Given this list of marker genes RABL6, OTX2, GOLGA1, EMX2 (empty spiracles homeobox 2), EZH1, TMCC1, PPP1R10, SMAD1, TUG1 (taurine up-regulated 1), IBSP, HOXC4, OTX1, NCDN, IP6K2, SLC12A5 (NCBI Gene Id 57468, solute carrier family 12 member 5), VAX1, OTP, NTF3, TMEM47, LGI1, TAF10, TSHZ2 (teashirt zinc finger homeobox 2), VCPKMT, ATXN7L2, CPNE1, SUMO1 (small ubiquitin like modifier 1), LINC03122, TRERF1, SCN4B, ERRFI1, HESX1, BRMS1L, ENPEP, SLC10A7, HMCN1, TMEM229B, CACNA1D (NCBI Gene Id 776), WIPI2, CYP26B1 (cytochrome P450 family 26 subfamily B member 1, NCBI Gene Id 56603), MBOAT2, MXRA8, OPA3, RASSF2, NLGN3, PFDN6, FAM81B, FOXP2, RAB9A, KRTAP17-1, MAPK10, SLIT3, PDZRN4, KCTD12, ZFYVE1 (zinc finger FYVE-type containing 1), SUMO4, ESM1, ITGB3BP, CASK, ARHGEF2, DPYSL2, DOCK3, C7orf33, SLC38A2, BCL11B, UBE2H, SOX2, PHF21A, LHX9, ISG20, HHIP, TBX4, HTR1B, CILK1, SECISBP2, PMCH, BRIP1, PCDH7, CHD1, SLU7, AMDHD2, GRB7, FCHSD2, POU2AF1, MAPK3, DLG2, TACSTD2, ANKRD28, HOXC6, CREB5, TAF8, PPM1D, LINS1 (lines homolog 1), ASPA, ARFGEF1, PROX1 (NCBI Gene Id 5629), NSD3, LINC00474, TOB1, PTGR3, KRTAP5-5 (keratin associated protein 5-5), CLN5, FSTL1, WBP2NL, SOX14, C1QTNF3, NEDD4, ANGPTL1 (NCBI Gene Id 9068), RNF17, MSL3, TMEM147, ATP1B4, SLITRK6, SBF2, DOCK1, OMD, PIK3C2A, CITED2, NCAM1, LAG3, NR4A1, DUSP1, KCNIP4, EGR2, ARHGAP30, TSPYL2, SALL3, BDH1, WDR46, CD2BP2, RTRAF, MSMB, LAMC1, DNAJC5B, NFIB, SLC39A8, ATOH1, TAF5L, NEO1, SERTAD4, GRIK2, SNCAIP, C1QTNF6, PPP2R2B, MCC, NPM3, CLIP2 (CAP-Gly domain containing linker protein 2), INHBA, CRH, TOGARAM2, TLK1, CIMAP1C (NCBI Gene Id 161753), PPP2R3A, GPX1, PRDM1, ARRDC1-AS1, MSI2, ELF1 (E74 like ETS transcription factor 1), HHEX, FEZF2, ZBTB22, VIT, RAD21, RFTN2 (raftlin family member 2), TRIM8, WNT2, CREBRF, PRR34, HOXA11, BCL11A, HR, MRPS18B, PPP1CB, LMO4, CYRIA, SHANK2, GRIK3, RALYL, DMD, MORC1, ARL4C, TMEM187, CLDN8, HOXA10, ATP2A2, IMPDH2, POU3F4, MYL1, FST, EIF4EBP2, LINC00173, DNAJB12, CAPN3, ING3, SLC6A14, NTN1, ZBTB37 (zinc finger and BTB domain containing 37), STAG2, SEMA6D, EFEMP1, ELAVL2, NRP1, ASB7, FGF9, BUB3, HOXB8, PRRC2C, PURA, TIMM8A, NIPBL, CSNK1G3, IRS4 (NCBI Gene Id 8471), EFNA5, KLF12, ARHGEF17, FOXD3, HSD11B1, RPS6KB1, SLC16A6, PIM1, RTL9 (NCBI Gene Id 57529), NIN, CSRNP3, SHKBP1, NEUROD4, ETV5 (ETS variant transcription factor 5), PRKAG1, IL25, SSBP3, FOXB1, RBFOX1, SCG3, DTNA, CNBP, NTN5, SATB2, HOXB4, PLPPR2, RREB1, CCDC117, PHEX, PITX2, LINC00649, KCNQ5, GTF2A1, RUNX1T1, NR4A2, NSG2, ZBTB18, AP1G2, PHF8, LCP2, here is a description of the gene set: Human Gene Set: HFH1_01 Genes having at least one occurrence of the motif NATTGTTTATWT in the regions spanning 4 kb centered on their transcription starting sites. This matches the FOXQ1 transcription factor binding site V$HFH1_01 (v7.4 TRANSFAC). species: Homo sapiens